The following is a description of a gene set: species: Mus musculus Mouse Gene Set: GOBP_NEGATIVE_REGULATION_OF_LYMPHOCYTE_ACTIVATION Any process that stops, prevents, or reduces the frequency, rate or extent of lymphocyte activation., and this is the list of marker genes: Pawr (PRKC, apoptosis, WT1, regulator), Il20rb, Pglyrp2, Cbfb, Glmn, Id2, Spn, Flt3, H2-T23, Lyn, Tarm1, Pde5a, Erbb2, Vsig4, Ctsg, Arg1, Lag3, Socs6, Casp3, Pdcd1lg2, Prdx2, Sdc4, Crtam, Vsir, Ripor2, H2-M3, Tbc1d10c, Dusp3, Dusp22, Zbtb7b, Loxl3, Ctla4, Ifnb1, H2-Aa, Lgals1 (NCBI Gene Id 16852), Rc3h1, BC037156, Ceacam1, Cd44, Marchf7, Tnfaip3, Lst1, Runx1, Ildr2, Scrib, Zc3h8, Adora2a, Bmp4, Btla, Pglyrp4, Cdkn2a, Il4ra, Lilrb4a, Tnfrsf21, Itch, Cd274, Ptpn2 (NCBI Gene Id 19255), Pglyrp3, Mad1l1, Mdk, Pag1, Inpp5d, Cblb, Ndfip1, Zfp608, Il2ra, Sfrp1, Bcl6, Tigit, Fas, Fgl2, Sftpd, Foxj1, Sox11 (SRY (sex determining region Y)-box 11), Pla2g5, Ptpn22, Dlg1, Lilrb4b, Samsn1, Nrarp, Socs5, Prkar1a, Cd37, Lgals9, Socs1, Dapl1, Tspan32, Cd69, Cebpb, Tbx21, Twsg1, Havcr2, Cd276, Vtcn1, Laptm5 (NCBI Gene Id 16792), Pglyrp1, Pibf1, Hfe, Clec4g, Dtx1, Tnfrsf14, Cd300a, Tsc2, Pten, Ufl1, Il4, Hspb1 (NCBI Gene Id 15507), Pf4, Runx3, Gimap5, Gnrh1, Il2, Tyrobp, Ihh, Dlg5, Arg2, Hlx, Nfkbid, Lax1, Cd74, Slfn1, Bank1, Jak3, Tnfrsf13b, Foxp3, Tmem131l, Clec12a, Pla2g2a, Pla2g2f, Gli3, Ido1, Gpnmb, Rassf5, Irf1, Zc3h12d, Rag2, Clnk, Btn2a2, Smad7, Tnfaip8l2, Anxa1, Fcgr2b, Rhbdd3, Cd24a, Gal, Il10, Il4i1 (NCBI Gene Id 15088), Tnfsf18, Zfp35, Tnfsf4, Axl (NCBI Gene Id 26362), Slc4a2, Btk, Tgfb1, Lrrc32, Lgals3, Pdcd1, Ascl2, Rc3h2, Prnp, Tyro3, Fgl1, Hmgb3, Fbxo7, Fgr, Ptpn6, Cd86, Xcl1, Zc3h12a, Scgb1a1, Peli1, Pla2g2d, Mill1, Atm, Hmgb1, Parp3, Mertk, Shh, Gimap3 (GTPase, IMAP family member 3), Pkn1, Cd80